Given this list of marker genes ALDH3B2, SULT1C4, SULT1E1, ACSS2, ADH4, SULT1A2, SULT1A1, ACSS1, SULT1A3 (NCBI Gene Id 6818), ALDH2, ALDH1B1, SULT1B1, SULT2A1, ALDH3B1, SULT1A4, here is a description of the gene set: The chemical reactions and pathways involving ethanol, CH3-CH2-OH, a colorless, water-miscible, flammable liquid produced by alcoholic fermentation. studied in species Homo sapiens Human Gene Set: GOBP_ETHANOL_METABOLIC_PROCESS